The following is a description of a gene set: Neighborhood of PAX7 Neighborhood of PAX7 paired box gene 7 in the MORF expression compendium Human Gene Set: MORF_PAX7 studied in species Homo sapiens, and this is the list of marker genes: KRT1, C1orf216, SLC4A3, ZNF592, RREB1, FLT1, AMFR, TNFRSF25, TENM4, ADCYAP1, MSX1, CPZ, ZBTB14, GNPAT, SDC3, GRIP2, NOS2, ENOX2, CLOCK, ELL2, GPR15, KCNA5, CRHR1 (NCBI Gene Id 1394), EGR1, BARX2 (NCBI Gene Id 8538), MSL3, LPGAT1, HCRTR2, NR2F1, BCL2, ZNF202, KRT33A, ZNF330, CCIN, PAX7, TRIO, CAMK2G, RUNX1, MSH3, MDM2, ZNF710, AQP7, GMPR, NCKIPSD, ATXN3, SRPK3, GABRB2, ERC1, RXRG, PDE6A (NCBI Gene Id 5145), KRT33B, GPR18, PRELID3A, SLC46A3, SLC30A3, ATP8A2, BRD4, ATP6V0A2, DAPK2, POLR1HASP, MAGEA9, ATF2, PPP2R5B, ANXA10, PSG1, MC5R, STK17A, SYNJ2, ZNF157, NXPE3 (neurexophilin and PC-esterase domain family member 3), FNTB, MINDY2 (NCBI Gene Id 54629), MAGI1, CDC73, PTPRS, CD6, HTR1E, DNAJC16, HOXD4, UBE4B, ESR1, CYP2E1, IL4, RFC5 (replication factor C subunit 5), RPH3A, CCR3, MC2R, MYT1, PPP1R12B, SLC15A1, HAAO, POU6F2, ETV3, CADM4, SUPT3H, CMKLR2, RPS6KB2, SFRP4, TBX19, PLEKHB1, COLGALT2, ATP10B, KLRC4, NPFF, DPT, MPZL1, SCN7A, GPR19, KRT2, GRIK5, PART1 (NCBI Gene Id 53948), BRCA1, WBP4, ARFGEF2, VKORC1, ABCB9 (NCBI Gene Id 23457), SIX3, EPHB2, BMP10, PIGR, RAD51D, COLQ, ATP2B2, NPAS2, HABP4, DRC3, TBXT, HOXC11, AMMECR1, FGA, ITIH4, HNF1A, SLC2A1, ZNF132, CBLN1, MYH2, TSPYL1, MYC, EDIL3 (NCBI Gene Id 10085), ZSCAN26, SLC13A2, AQP5, BNIP1, TMEM26, EXOC4, CFH, GLE1, ERCC4, SIX6 (SIX homeobox 6), RALYL, SLC17A1, NTNG2, RSC1A1, RAC3, ELAVL2, LECT2, IPO9, CYP11A1, NRTN, POU6F1, CYP2D6, WT1-AS, KANK2, PHLDB1, POLR2K, STXBP5L, SULT4A1, ADCY3, ABCC8, TBC1D22A, CDH4, MAP2K7 (mitogen-activated protein kinase kinase 7), PVR, AOC4P, SIM2, DEPDC5, NR3C2, FGF18, SERPINA4, LTBP4, SYT5, NFIC, FZD5, AFF2, GCM1, SCAPER, ENTPD1, CTRL, SLC17A7, CNKSR1, CSRP3, ABO, COL19A1, ARL3, RB1CC1, STAC, TACC2, SLC17A3, PLXNA3, COX6A2, MLLT10, ZBTB40, FOSL1, KAZN, LILRA4, IL3, GJB5, SLC18A1, MID2, CD3E, PSD, DGCR5, ZNF133, MLN, TNK1, ATP8B1 (NCBI Gene Id 5205), NTPCR, ZNF500, ABCA1, ADAM20, ROR2, STARD5, NR1I2, HTR1B, NEB, THRA, FUT6, MON2, RUNX2, HMHB1, SEZ6L, CEP135, FIG4, TRIM24, PDE4D, JADE3, OR2B6, PAX9, ECM2, MYOZ3, LINC00837, SOAT2, IVL, CEP162, BCL2L11 (NCBI Gene Id 150819), S100A5, CPB2, PAX6, PAXIP1, AKAP3, P2RY10, SLC14A2, SLC16A5, KRT86, GNG4, TBX5, KAT8, KRR1, CACNB1, CBARP, MYO9B (myosin IXB), HTR4, CAMK4, POFUT2, PHF10, SLC22A6